The following is a description of a gene set: from publication Yevshin I, Sharipov R, Kolmykov S, Kondrakhin Y, Kolpakov F (PMID 30445619) Mouse Gene Set: ZFP990_TARGET_GENES studied in species Mus musculus, and this is the list of marker genes: 9530082P21Rik, Gm26885, Mir654, Gm16096, Wsb1, Cp, Mir7675 (NCBI Gene Id 102465775), Lrriq4, Pde7b (phosphodiesterase 7B), Mfsd11, Foxc1, Gm15032, Mgat5, Best2, Shmt1, Vps72, Tmem161a, Capza1, Gm12980, Prrc2a, Hilpda, Tmem242, Gm9359, Mir6405, Lrp11, Sqstm1, Rassf9, Entpd1, Fry, Trmt61a, Maea, Zfp212, Ccer2, Exosc1, Alg11, Hmgxb4, Slx4, Ankrd40, Tdrd9, Syt8, Gpr107, Ninj2, Mrpl30, Rpl10-ps2, Ube2c, Omg, Vac14, Mir376a, Gm14964, Snph, Mov10l1, Sv2b, Tpcn2, Myo15a, 1700094J05Rik, Gm11198, Zbtb8a, Snora81, Hook1, Mlxip, 4930515G01Rik, Gm23706, Gm12727, Rdm1, Plekhb1, Med18, Gm1818, Gm11475, Phf20, Cyb5r1, Gm37885, Gm12610, Gm15413, Scn9a, Fuca1, Cse1l, Slc25a13, Oaz2-ps, Ccsap, Fam131a, Thap6, Aldoa, Or7c74 (NCBI Gene Id 545417), Atp6v0a1, Lag3, Inpp5b (NCBI Gene Id 16330), Tamm41, Pzp, Lgmn, Bcas1, Gm26447, Igf2bp2, Gm12687, Tmem61, Mlkl, Git2, Gm12125, Gm10268, Aloxe3, Gm25137, Habp2, Urgcp, Snrnp25, Mpi (mannose phosphate isomerase), Ltbp1, Gm2990, Mms19, Slco1c1, Fanca, 5930420M18Rik, Gm14987, Camsap1, Smpd5, Or6c8, Uba2, Tnfrsf1a, Gm13662 (predicted gene 13662), Doc2g, Serpinc1, Cyp7a1, Fbll1, Cdr2l, Uts2r, Terf2, Nono, Lsm4, Srebf1, Dlat, D030068K23Rik, Mrpl14, Dcakd, Lima1, Rhbdl3, Sart1, Zbtb43, Trmt112-ps2, Polr3a, Gnpat, Susd6, Hlf, Nrdc (nardilysin convertase), Lbhd1, Sipa1, Glis3, Dnm2, Nbeal2, Meox1, Prss54, Akap13, Fam83c, Crot (carnitine O-octanoyltransferase), A630072M18Rik, Snf8, Rcbtb1, 4933440N22Rik, Gm14162, Mir376b, Klhl12, Gm34248, Taf6l, Syne4, Ctbp2, Mycbp2, Serpine2, Gm11292, Ms4a12, Sergef, Gm14175, Scd4, Phox2b, Rhbdf2, Rhbdl2, Kntc1, Ppfia1, Plekha6, Bmp8b, Mettl8, Tbc1d9b, Gm22122 (predicted gene, 22122), Nos1, Efna3, Pik3r1 (NCBI Gene Id 328326), S1pr4, 1500012K07Rik, Hgd, Rtl1 (retrotransposon Gaglike 1), Ralgapb, Car3, Gm4847, Phyh, 1700101I11Rik, Lcp1, Ndufa12-ps, Tbx3os1, Il17f, Gm9955, Uba52, Ctsa, Ptbp1, Cars1, Cirbp, Tekt5 (NCBI Gene Id 70426), Gm15927 (predicted gene 15927), Rpl5, Nrbp1, Abca16, A330048O09Rik, Mmp19, Utp25, Gm7097, Gm23605, Zic2, Gm8213, Tmed2, Slc1a1, Zc3h18, Gm25917, Mir3108, Sirt7, Plaa, Ash2l, Aatf, P2rx7, Asb6, Vmn1r-ps149, Gfm1, Prpf38b, Itpr2, Myh14, Smarcd3, Il25, Papola, Fbrsl1, Nemp1, Gm10729, Tap2, Znrf1, Tm4sf5, Cip2a, Pdcd6ip, Mir1199, Tagln2, A330102I10Rik, Cpne5, Gm22272, Oas2, Jak1, Btbd19, Ankzf1, Pik3ap1, Slc12a5, 2210417A02Rik, Tank, Mrpl10, Rpl35a-ps6 (ribosomal protein L35A, pseudogene 6), Cln3, Bbs9, Olig3, Gpr85, Nabp2, Garnl3, Slc38a8, Lpin2, Med1, Gm6096, Pnpla3, Gm5865, Gm24616, Cope, Eif4a2, Mir3475, Ly6g6f, Lrsam1, Zfp318, Resf1, Ift122, Gm12740, Dis3l, Ezh1, Gm24296, Pate2, Rpl22, Misp3, Trpm1, 1700003F12Rik, Gm24400, Psma3